Given this list of marker genes C21orf58, WDR47, ARL1, MED27, MOSMO, TAPT1, SUV39H2, RFX3, BRSK2, NRAS, RIF1, MYLIP, UBIAD1, UBE3A, NUS1, RHOB, SHANK2, HAPSTR1, HOXA2, CHD4, RFC1, TEPSIN, ARF1, POLK, GNAI2, ZNF644, SMYD5, SUPT16H, PSMD8, RAB22A, CYB5D2, EPC1, MAFA, CDKN2C, BABAM1, PPM1E, NASP, RLIM, RALA, UBR5, IRAK1, RBM26, HTN1, XCL2, ATF1, PCIF1, ZNF326, CDC42BPB, STAU1, HOXA9, CCDC186, APBA1, TTBK2, TRIM8, CLSTN1, BCL2L2, CNOT3, TAPT1-AS1, RPS27, SNX13, DNAJC7, MIR9-1HG, BNC2, ZBTB4, PAX6, KNL1, CERT1, ADAMTS9, TIA1, MED1, HMGXB4, OSR1, SLITRK3, PPP1R12B, ANKHD1, PIGN, CAMKMT, RBM3, PRMT1 (protein arginine methyltransferase 1), POLR2A, TMEM187, EIF5, LRRN3, FKRP, CCDC71L, ARCN1, RNF26, PRDM1, ANKHD1-EIF4EBP3, OTX1, HOXB6, CXXC1, ZZEF1, ATG2B (NCBI Gene Id 55102), STRN4, CNOT4, TSC1, PLAG1, UBXN11 (UBX domain protein 11), NEUROD1, PHF8, WDR33, MRPL38, VAMP2, CHCHD7, SFPQ, NFYC, ANKRD28, UBE2D3, PRRC2C, ZBTB22, RAB1B, REXO1, SFN, NKIRAS2, EP300, PCNT, HOXC10, PREPL, YY1, RAD23A, ZC3HC1, FMO5, here is a description of the gene set: Comprehensive identification of all functional elements encoded in the human genome is a fundamental need in biomedical research. Here, we present a comparative analysis of the human, mouse, rat and dog genomes to create a systematic catalogue of common regulatory motifs in promoters and 3' untranslated regions (3' UTRs). The promoter analysis yields 174 candidate motifs, including most previously known transcription-factor binding sites and 105 new motifs. The 3'-UTR analysis yields 106 motifs likely to be involved in post-transcriptional regulation. Nearly one-half are associated with microRNAs (miRNAs), leading to the discovery of many new miRNA genes and their likely target genes. Our results suggest that previous estimates of the number of human miRNA genes were low, and that miRNAs regulate at least 20% of human genes. The overall results provide a systematic view of gene regulation in the human, which will be refined as additional mammalian genomes become available. Human Gene Set: AAGWWRNYGGC_UNKNOWN Genes having at least one occurrence of the highly conserved motif M63 AAGWWRNYGGC in the regions spanning 4 kb centered on their transcription starting sites. The motif does not match any known transcription factor binding site. species: Homo sapiens from publication Xie X, Lu J, Kulbokas EJ, Golub TR, Mootha V, Lindblad-Toh K, Lander ES, Kellis M (PMID 15735639)